The following is a description of a gene set: Human Gene Set: GOBP_TRANSFORMING_GROWTH_FACTOR_BETA_RECEPTOR_SIGNALING_PATHWAY species: Homo sapiens The series of molecular signals initiated by an extracellular ligand binding to a transforming growth factor beta receptor on the surface of a target cell, and ending with the regulation of a downstream cellular process, e.g. transcription., and this is the list of marker genes: VASN (vasorin), HSPA1A, MIR106A, MIRLET7B, SDCBP, CIDEA, SMAD9, PEG10, SKOR2, LRG1, CILP, MIRLET7G, BRMS1, ONECUT1, APOA1, HIPK2, NREP, MIR20A, MIR497, ING2, MEN1, ADAMTSL2, LRRC32, BCL9, MYOCD, MIR564, GLG1, NLK, IL17RD (interleukin 17 receptor D), MIR181A2, MIR142, MIR27B, TET1, TGFB2, SELENON, ZMIZ2, MAP3K7, DUSP22, AMHR2, SMAD3, STUB1, MIR29B1 (NCBI Gene Id 407024), RBBP4, FBN1, APPL1, ERO1A, SMAD2, NKX2-1, SIN3A, BMPR1A, DAB2, CD109, CITED1, CDH5, HSPA5, ACVRL1, GCNT2, PPARG, TGFB1, ITGB8, ENG, SRC, CDKN2B, SMURF1, MIR373, TRIM33, MIR9-1, STAT3, HTRA3, GDF10, CLDN5, GDF5, LTBP2, VEPH1, ING1, RASL11B, DAND5, OVOL2, LTBP3, LOX, BMP2, PML, USP9X, ZFYVE9, CAV2, WNT1, FERMT2, LDLRAD4, SAP30, HDAC1, PTK2, MIRLET7A1, WFIKKN1, LATS1, PBLD, SMAD6, IL17F, SPRED3, ITGB1, FOLR1, CITED2, COL1A2, LEMD3, MIR30B, FKBP1C (FKBP prolyl isomerase family member 1C), MIR26A1, FSHB, MIR212, FAM89B, HSP90AB1, EP300, SNW1, PARP1, BCL9L, SAP30L, CHST11, ARID4A, PIN1 (NCBI Gene Id 5300), FERMT1, STK11, ADISSP, GDF15, TSKU, ZNF451, MIR30A, SKIL, NRROS, USP9Y, CREB1, USP15, ZEB1, MIR490, MIR520C, MIR101-1, SMAD4, PRDM16, PMEPA1, MIR361, AXIN1, TWSG1, MIR424, TGFBR3L, FKBP1A, MIR21, SPRED2, CREBBP, SMAD5, MSTN, LTBP1, FLCN, BAMBI, MIR93, SUDS3, TGFBR2, PPM1A, ONECUT2, SIRT1, HTRA4, MIR15B, MIR19B1, PXN (paxillin), MIR18A, ITGA3, PPARA, LATS2, ID1, FBN2, TGFBR1, TGFBRAP1, ITGA8, ACVR1, SINHCAF, FURIN, DKK3, ITGB6, XBP1, RNF111, MIR199A1, SMURF2, MIR302B, MIR323A, TSC22D1, CDH3, PIAS2, SNX6, TGFB1I1, MIR342, LTBP4, ADAM17, TP53, MIR140, NODAL, FUT8, ZBTB7A, ARID4B, INTS9, COL3A1, TGFB3, FMOD, MIR376C, MIR98, GDF9, MIRLET7F1, SMAD1, GOT1, ADAM9, LPXN, BRMS1L, MIR498, ZMIZ1, HPGD, HTRA1, SNX25, FOXH1, ITGB5, MIR372, RBBP7, FOS, MECOM, OGT, ARRB2, SPI1, SPRY2, MIR204, ASPN, APPL2, TGFBR3, LEFTY1, MIR17, MIR183, FNTA, ZNF703, PSG9, MIR145 (microRNA 145), SAP130, MTMR4, CDKN1C, HDAC2, GIPC1 (GIPC PDZ domain containing family member 1), JUN, PDPK1, ZEB2, SOX11, CAV3, NPNT, ZYX, EID2, MIR19A, SKI, RGCC, TAB1, SMAD7, STRAP, PTPRK, SPRED1, WFIKKN2, EMILIN1, PALS1, SLC2A10, SPRY1, NDP, THBS1